The following is a description of a gene set: studied in species Homo sapiens Pathway Definition from KEGG: TAX -| TP53 => CDKN1A -| (CDK2+CCNE) -> RB1 // E2F Human Gene Set: KEGG_MEDICUS_PATHOGEN_HTLV_1_TAX_TO_P21_CELL_CYCLE_G1_S_N00497 HTLV-1 Tax to p21-cell cycle G1/S. Pathway ID: N00497. Pathway type: Pathogen. Pathway class: nt06160 Human T-cell leukemia virus 1 (HTLV-1)., and this is the list of marker genes: RB1, E2F3, CCNE1, E2F1, CCNE2, E2F2, CDK2, CDKN1A, TP53